The following is a description of a gene set: species: Homo sapiens from publication Vecchi M, Nuciforo P, Romagnoli S, Confalonieri S, Pellegrini C, Serio G, Quarto M, Capra M, Roviaro GC, Contessini Avesani E, Corsi C, Coggi G, Di Fiore PP, Bosari S (PMID 17297478) Human Gene Set: VECCHI_GASTRIC_CANCER_EARLY_DN Gastric carcinoma is one of the major causes of cancer mortality worldwide. Early detection results in excellent prognosis for patients with early cancer (EGC), whereas the prognosis of advanced cancer (AGC) patients remains poor. It is not clear whether EGC and AGC are molecularly distinct, and whether they represent progressive stages of the same tumor or different entities ab initio. Gene expression profiles of EGC and AGC were determined by Affymetrix technology and quantitative polymerase chain reaction. Representative regulated genes were further analysed by in situ hybridization (ISH) on tissue microarrays. Expression analysis allowed the identification of a signature that differentiates AGC from EGC. In addition, comparison with normal gastric mucosa indicated that the majority of alterations associated with EGC are retained in AGC, and that further expression changes mark the transition from EGC to AGC. Finally, ISH analysis showed that representative genes, differentially expressed in the invasive areas of EGC and AGC, are not differentially expressed in the non-invasive areas of the same tumors. Our data are more directly compatible with a progression model of gastric carcinogenesis, whereby EGC and AGC may represent different molecular stages of the same tumor. Finally, the identification of an AGC-specific signature might help devising novel therapeutic strategies for advanced gastric cancer. Down-regulated genes distinguishing between early gastric cancer (EGC) and normal tissue samples., and this is the list of marker genes: TMPRSS15, UBE2J1, KLF15, PLLP, PTGDR2, ADTRP, NT5DC1, FCRL5, ARMCX2, MAP7D2, IGHA1, ZBTB16, RAI2, SSTR1, CLU, KLF9 (NCBI Gene Id 687), PLP1 (NCBI Gene Id 5354), SPART (NCBI Gene Id 23111), ADGRL3, HLA-DOB (NCBI Gene Id 3112), SMIM38, SLC28A2, NR3C2, CYTIP, ASPA, SELENOP, IRX3, SOBP, STAP1, SHISA3, RBPMS2, LIFR, TMT1A, THSD4, NTN4, REG1A, CKMT2, P2RY14, PWWP3B, SLC18A2, ASAH2, IGKV1D-13, MT1M, UNC5D (unc-5 netrin receptor D), SOX6, TCEAL2, ZNF471, NCAM1, VLDLR, TMEM47, C6, GC, PRKD3, WIF1, PTPRZ1, SNHG14, FAM3B, SLC16A7, CHRM3, AKR1C1, LARP6, SCUBE2, SPINK2, ATP13A4, SLC51A, CHGA, GAS1, IGKV1D-37, FAM30A (family with sequence similarity 30 member A), IDUA, NR3C1, SULT2A1, FHL1, MZB1, RGMB, PRDM16, GREM2, RNLS, PALM2AKAP2, UBE2QL1, DPT, CXCL12, SCGB2A1, GHR, BPIFA1, ERO1B, BHLHA15, SRPX, NAP1L2, CCR2, ATP4A, GIP, CD36, FMO5, ACKR4, GSTA1 (glutathione S-transferase alpha 1), CNN1, CFL2, GLUL, SCARA5, PDGFD, HLF, ALDH6A1, DAB1, AQP4, ARHGAP24, MAOA, RETNLB, SLC2A2, CYP2C18, RCAN2, GABRB3, LINC02381, KCNE2, SETBP1, ENPP2, RGS4, SLAMF7, TENT5C, MAP9, SCN7A, PDK4, ECHDC3, GATA5, UBL3, PPP2R3A, GSTA3, CPE, GRIP2, CFH, MFSD4A, LDHB, MAGEH1, CLDN10, PLN, CNTN1, COLCA1, CEP85L, CITED2, IGKJ5, UGT2B15, PELI2, GADD45B (NCBI Gene Id 4616), SULT1B1, ARRDC4, ETNPPL, NME5, ANGPT1, ADRB2, MYRIP, MCTP1, MYOC, BEX2, CWH43, ZNF677, BEX5, RASSF10, CPA2, ELAPOR1, UGT2B17, PBLD, FKBP5, ITM2A, ADIPOQ, AMPD1, MFAP5, CDH19, JAM2, LAMA2, ARMCX1, VEPH1, PLCXD3, ZNF844, F13A1, ACE2 (NCBI Gene Id 59272), GNAO1, SUSD4, MT1E (metallothionein 1E), GKN2, CCPG1, MT1H, MAMDC2, F11, ADA (NCBI Gene Id 100), KIF5C, ADH1B, ZNF385B, LONRF2 (NCBI Gene Id 164832), ST8SIA4, CAVIN2, ST3GAL6, RPS6KA6, C16orf89, ADGRG2 (NCBI Gene Id 10149), SULT1E1, COL4A6, RBP2, SEMA4A, PGC, POU2AF1, MT1X, CD302, SYT4, SLC26A7, PCDH9, CYBRD1, RAB27A, APOA1, LY9, DMD, IGKV1OR1-1, SVEP1, AGTR1, GPR155, PDGFC, PCDH20, LYVE1 (lymphatic vessel endothelial hyaluronan receptor 1), PGA5, PKIB, FABP4, KIT, GCNT2, SLC1A2, BNIP3, SNX24, KCNJ16, IL6R, ENTPD5, YIF1B, ID4, PNOC, GSPT2, PRIMA1, ENTPD3, CGNL1, ERBIN, SORBS2, ALDH1L2, PRKACB, PID1, SLC15A1, BEX1, KCNJ5, FAM107A, USP51, BCHE, EFEMP1, PTGER3, IGLV3-25, ELL2, CLTRN, PPOX, ANGPTL1, CLDND1, IRX2, LINC00261, FUT9, SIDT2, TNFRSF17, GMPR, DTNA, LRRC17, SBSPON, MYOT, TMED6, OMD, CYP2C19, MAGI2, EVI2B, GPR27, CYP2C9, PLIN1, EBF1, ALDH1A1, HPGD, ABAT, NLRP7, CCL5, GPM6B, CHGB, GPER1 (NCBI Gene Id 2852), AFF3, PGM5-AS1, TRG-AS1, GPX3, DNAJC6, APOC3, SYNPO2, AADAC, STOX2, PRDM16-DT, GNG7, MAF (MAF bZIP transcription factor), SOSTDC1, JCHAIN, SNRPN, SPESP1, ATP4B, GKN1, SOX2, RAB9B, CHRDL1, ATP1A2, TSC22D3, SLC2A12, SERPINI1, JHY, KCNJ15, ECRG4, DUSP5 (dual specificity phosphatase 5), ATOSA, UGT2B11, LDB3, ZNF667-AS1, GABARAPL1, MT1F, LINC00667, MTTP, KANK4, IGKV1D-39, NEXMIF, HDGFL3, IGHM, TRGC1, LEPR, VSTM2A, ALDH1A2, C7, RORA, MEP1B, SH3GL2, ACOX2, HHIP, SST, RBMS3, SMARCA1, TTLL7, CYP3A4, WIPF3, RNF180, ABCA8, TMPRSS6, SLIT2, MANEA, IGLC2, CBLIF, DNER, TMEFF2, C14orf132, SLC36A4, HMGN5, SFRP1, MAL, PIK3CG, LIPF, KCNMB2, TMEM100, MDFIC, CYP1B1, FIGN, CD79A, ESRRG, PLPP3, RIMS3, NDNF, BEND5, ITIH5, SMLR1, ALKAL2, INA, SYNM, RGS13, SEPTIN6, CASQ2, SMIM11, NTRK3, BMPR1B, DTNB-AS1, HSPB8, NLRX1, PCDH7